The following is a description of a gene set: Any process that results in a change in state or activity of a cell or an organism (in terms of movement, secretion, enzyme production, gene expression, etc.) as a result of a reactive oxygen species stimulus. Reactive oxygen species include singlet oxygen, superoxide, and oxygen free radicals. species: Homo sapiens Human Gene Set: GOBP_RESPONSE_TO_REACTIVE_OXYGEN_SPECIES, and this is the list of marker genes: ANKZF1, CASP3, DHFR, IL18RAP, PCGF2, PRDX5, PTPRK, PCNA, DUSP1, BCL2, HSF1, GPR37L1, BECN1, CRYAB, NET1, PLK3, SOD1, TRPC6, MAP2K4, FYN, ADAM9, ATM, PRDX3, KPNA4, RPS3, MAPT, PEX5, PRKCD, SESN2, APOE, PINK1, CRYGD, TET1, AKT1, TPM1, PJVK, GCH1, APOA4, CAT, MIR21, FABP1, CYP1B1, MMP2, TXNIP, ZNF580, PDGFRA, PDCD10, STK25, TRAP1, PEX13, KLF4, SOD3, HIF1A, ADCYAP1R1, DHFRP1, ENDOG, PDK2, BMP7, TRPA1, ABL1, CD36, MPV17, ADPRS, TACR1, AREG, HMOX1, HDAC6, TREX1 (NCBI Gene Id 82474), HGF, NUDT15, GATA5, AMBP, S100A7, CRK, PEX10, AGAP3 (NCBI Gene Id 83883), MYB, FCHSD1, PRDX1, PRDX2, ATP7A, IL6, GPR37, CRYAA, BNIP3, SRC, EZH2, HBA1, COL6A1, PPP1R15B, MAPK7, ERN1, GPX1, BAK1, TOP2B, MB, HP, SESN1, NR4A3, KCNA5, MIR17, RLIG1, RIPK3 (NCBI Gene Id 11035), ABCC9, HDAC2, PAWR, SIRPA, NFE2L2, FBLN5, ERCC6, MIR133A1, SLC8A1, PPP2CB, OSER1, MMP3, APOD, MPO, SMPD3, MAP3K5 (mitogen-activated protein kinase kinase kinase 5), PPP5C, HBA2, FOXO3, NQO1, TNFAIP3 (TNF alpha induced protein 3), MT-ND5, RHOB, CAMKK2, MDM2, PKD2, GSTP1, KDM6B, SPHK1, RIPK1, BTK, ECT2, PEX12, FOXP1, EDN1, CAPN2, ERCC6L2, UCP3, CCS, PARK7, MIR34A, MIR103A1, HYAL1, TXN, MAPK8, TRPM2, NPPA, RACK1 (NCBI Gene Id 90938), FOS, SOD2, MET, OGG1, PPIF, RELA, SESN3, SCGB1A1, LRRK2, SETX, NME8, MIR107, EEF2, PEX14, MT3, PDGFD, MAPK9, AQP1, MIR92A1, COA8, TXNRD2, HBB, FXN, ROMO1, PLEKHA1, STAT1, FER, KLF2, CDK1, ZNF277, UCP2, MIRLET7B, COL1A1, PTPRN, DDR2, PPEF2, MAP1LC3A, PEX2, HYAL2, NOS3 (NCBI Gene Id 4846), PXN, CFL1, IL18BP, CDKN2A, CBX8, PRKAA1, LCN2, PRKCA, AIFM1, UCP1, SIRT1, CYGB, MAPK13